The following is a description of a gene set: The process by which the mitochondrial outer membrane becomes permeable to the passing of proteins and other molecules from the intermembrane space to the cytosol as part of the apoptotic signaling pathway. Human Gene Set: GOBP_MITOCHONDRIAL_OUTER_MEMBRANE_PERMEABILIZATION species: Homo sapiens, and this is the list of marker genes: TMEM102, BNIP3L, SIVA1, EYA2, SLC25A6, TMEM14A, SLC25A31, RHOT2, ZNF205, BNIP3, GCLC, BID, BLOC1S2, CHCHD10, HSPA1A, GSK3B, LRRK2, HIP1R, BOK, BCL2L1, IER3, RTL10, MUL1, SLC25A4, VDAC2, RHOT1, MPV17L, FZD9, BAK1, ATP5IF1, SLC35F6, ACAA2, GSK3A, SLC25A5